Given this list of marker genes Dmd, Cldn1, Agt, Ren1, Hapln2, here is a description of the gene set: The establishment of the barrier between the perineurium of peripheral nerves and the vascular endothelium of endoneurial capillaries. The perineurium acts as a diffusion barrier, but ion permeability at the blood-nerve barrier is still higher than at the blood-brain barrier. studied in species Mus musculus Mouse Gene Set: GOBP_ESTABLISHMENT_OF_BLOOD_NERVE_BARRIER